The following is a description of a gene set: Mouse Gene Set: REACTOME_STIMULI_SENSING_CHANNELS studied in species Mus musculus Stimuli-sensing channels, and this is the list of marker genes: Fkbp1b, Calm3, Clcnka, Wwp1, Stom, Ano8, Mcoln3, Trpc6, Scnn1g, Slc17a3, Clca1, Tpcn1, Trpm8, Clca4b, Trpa1, Best1, Clca2, Slc9b1, Ubb, Sgk1, Raf1, Unc79, Trpv3, Calm2, Sgk3, Trpc5, Rps27a, Asic1, Ano2, Ripk1, Mcoln2, Mlkl, Clcnkb, Ano3, Trpc3, Trpv6, Trpm5, Ttyh3, Trpc7, Best3, Clcn4, Trpc1, Trpm4, Clcn2, Ripk3, Sgk2, Trpm6, Trpv4, Casq1, Trpv1, Nedd4l, Scnn1a, Asic4, Ano4 (anoctamin 4), Nalcn, Sri, Scnn1b, Clcn6 (NCBI Gene Id 26372), Ano10, Unc80, Ubc, Trpc4, Mcoln1, Trpc4ap, Trpm3, Asic5, Ryr1, Casq2, Ttyh2, Stoml3, Clcn1, Asic3, Ttyh1, Calm1, Asic2, Trpv5, Trpv2, Ryr3, Trdn, Ano9, Clcn5, Trpm2, Trpm1, Clcn7, Ano1, Best2, Uba52rt, Ano7, Bsnd, Asph, Ano6, Trpm7, Slc9b2, Ryr2, Ano5, Tpcn2, Uba52, Ostm1